The following is a description of a gene set: Localized thickening and tightness of the skin of the fingers or toes. Human Gene Set: HP_SCLERODACTYLY Sclerodactyly studied in species Homo sapiens, and this is the list of marker genes: RSPO1, LMNA, LBR, SMARCAD1, GJA1